The following is a description of a gene set: The elimination by an organism of the waste products that arise as a result of metabolic activity. These products include water, carbon dioxide (CO2), and nitrogenous compounds. species: Mus musculus Mouse Gene Set: GOBP_EXCRETION, and this is the list of marker genes: Cyp2j5, Edn1, Corin, Tacr1, Cacna1c, Slc22a6, Chrnb4, Psap, Sgpl1, Abcg3, Crhr2, Mdk, Lipa, Tiparp, Drd2, Ednrb, Chrna3, Mllt6 (myeloid/lymphoid or mixed-lineage leukemia; translocated to, 6), Chrnb2, Umod, Trpv1, Scn11a, Nr3c2, Arid5b, Myo1e, Stc1, Schip1, Kcnma1, Slc5a2, Abcg2, Spx, Pdgfrb, Atp6v0a4, Atp6v1b1, Ptger3 (prostaglandin E receptor 3 (subtype EP3)), Comt, Nherf1, Cln3, Npsr1, Zfp950